Given this list of marker genes PRKACB, RAPGEF3, PRKAR1B, IL1B, PRKAR2A, PRKAR1A, NLRP3, NEK7, here is a description of the gene set: species: Homo sapiens EPAC1 and PKA reduction of retinal inflammation Human Gene Set: WP_EPAC1_AND_PKA_REDUCTION_OF_RETINAL_INFLAMMATION